Given this list of marker genes SLC26A11, SLC26A3, SLC5A12 (solute carrier family 5 member 12), SLC26A7, SLC26A1, SLC26A4, SLC26A9, SLC26A2, SLC26A6, here is a description of the gene set: Multifunctional anion exchangers Human Gene Set: REACTOME_MULTIFUNCTIONAL_ANION_EXCHANGERS studied in species Homo sapiens